The following is a description of a gene set: Any process that results in a change in state or activity of a cell or an organism (in terms of movement, secretion, enzyme production, gene expression, etc.) as a result of a stimulus from a Gram-positive bacterium. studied in species Mus musculus Mouse Gene Set: GOBP_RESPONSE_TO_GRAM_POSITIVE_BACTERIUM, and this is the list of marker genes: Enpp1, Nfkbiz, Muc19, Cldn3, Il27 (NCBI Gene Id 246779), Fosl2